The following is a description of a gene set: Human Gene Set: ERWIN_COHEN_BLOOD_VACCINE_TC_83_AGE_23_48YO_VACCINATED_VS_CONTROL_14DY_DN from publication Erwin-Cohen RA, Porter AI, Pittman PR, Rossi CA, DaSilva L (PMID 27870591) Venezuelan equine encephalitis virus (VEEV) is an important human and animal alphavirus pathogen transmitted by mosquitoes. The virus is endemic in Central and South America, but has also caused equine outbreaks in southwestern areas of the United States. In an effort to better understand the molecular mechanisms of the development of immunity to this important pathogen, we performed transcriptional analysis from whole, unfractionated human blood of patients who had been immunized with the live-attenuated vaccine strain of VEEV, TC-83. We compared changes in the transcriptome between naive individuals who were mock vaccinated with saline to responses of individuals who received TC-83. Significant transcriptional changes were noted at days 2, 7, and 14 following vaccination. The top canonical pathways revealed at early and intermediate time points (days 2 and 7) included the involvement of the classic interferon response, interferon-response factors, activation of pattern recognition receptors, and engagement of the inflammasome. By day 14, the top canonical pathways included oxidative phosphorylation, the protein ubiquitination pathway, natural killer cell signaling, and B-cell development. Biomarkers were identified that differentiate between vaccinees and control subjects, at early, intermediate, and late stages of the development of immunity as well as markers which were common to all 3 stages following vaccination but distinct from the sham-vaccinated control subjects. The study represents a novel examination of molecular processes that lead to the development of immunity against VEEV in humans and which may be of value as diagnostic targets, to enhance modern vaccine design, or molecular correlates of protection. species: Homo sapiens Genes down-regulated in blood vaccinated vs control in adults (23-48) after exposure to Live attenuated vaccine TC-83, time point 14D, and this is the list of marker genes: SLC4A1, TNS1, OR2W3, SELENBP1, LINC01002, EPB42, PI3